Given this list of marker genes Cyp2w1, Cyp4v3, Aoc1, Cyp2c65, Cyp2e1, Cyp46a1, Cyp2a12, Ces1d, Cyp11a1, Tbxas1, Cyp2c29, Ahrr, Cyp26c1, Ahr (aryl-hydrocarbon receptor), Nqo2, Aldh3a1, Cyp27b1, Smox, Cyp19a1, Cyp4a10, Cyp3a44, Cyp2a22 (NCBI Gene Id 633450), Cyp7b1, Cyp2c66, Maoa, Cyp3a57, Ncoa2, Cyp3a16, Adh4, Ephx1, Aldh1a1, Aldh2, Mtarc1, Aoc3, Rxra, Ptgs1, Cmbl, Cyp3a13, Fdxr, Fmo3, Cyp27a1, Ces2b, Hsp90ab1, Fmo1, Bphl, Cyp3a25, Cyp39a1, Cyp4b1, Cyp2s1, Aldh1b1, Fdx2, Cyp4f15, Cyp3a11, Cyp11b2, Arnt, Nr1h4, Adh7, Cyp4a32, Cyp8b1, Cyp4a30b, Cyp2b23, Paox, Cyp4a14, Cyp7a1, Cyp2d22, Cyp4a12b, Maob, Acss1 (acyl-CoA synthetase short-chain family member 1), Cyp4f39, Cyp3a41a, Cyp4f14, Ces3a (carboxylesterase 3A), Acss2 (acyl-CoA synthetase short-chain family member 2), Aip, Cyp26b1, Cyp11b1, Ncoa1, Fmo2, Adh5, Aoc2, Cyb5r3, Cyp4a31, Cyp3a59, Cyp3a41b, Cyp2f2, Cyp24a1, Cyp2a5, Cyp51, Fdx1, Cyp2a4, Cyb5b, Cyp2u1, Cyp1a1, Cyp2j6, Cyp1a2, Mtarc2, Arnt2, Ptgis, Ptges3, Cyp21a1, Cyp2r1, Cyp4a12a, Cyp1b1, Adh1, Cyp4f18, Pomc, Ces3b, Cbr3, Aadac, Cyp4a29, Cyp4f40 (NCBI Gene Id 631304), Cyp26a1, here is a description of the gene set: Phase I - Functionalization of compounds species: Mus musculus Mouse Gene Set: REACTOME_PHASE_I_FUNCTIONALIZATION_OF_COMPOUNDS